The following is a description of a gene set: A process that modulates neuronal synaptic plasticity, the ability of neuronal synapses to change as circumstances require. They may alter function, such as increasing or decreasing their sensitivity, or they may increase or decrease in actual numbers. Mouse Gene Set: GOBP_REGULATION_OF_NEURONAL_SYNAPTIC_PLASTICITY studied in species Mus musculus, and this is the list of marker genes: Grin2d, Grik2, Gsg1l, Zdhhc2, Rims1, Unc13a, Nptn, Rasgrf1, Lnpep, Syp, Pmch, Drd2, Ncdn, Syap1, Hras, Syt4, Syngr1, Fcgr2b, Syngap1, Dlg4, Cln3, Vgf, Slc4a10, Shisa6, Mylk2, S100b, Nf1, Rab11a, Snca, Egr1, Agt, Cpeb1, Rab3gap1, Unc13b, Camk2b, App, Egr2 (NCBI Gene Id 13654), Grin2c, Ppfia3, Grm5, Rab3a, Camk2g, Rab5a, Rab8a, Kmt2a, Jph3, Star, Camk2d, Gsk3b, Shisa9, Arc, Syn1, Fxr1, Grin2a, Nsmf, Nog, Grin2b, Kcnn2, Camk2a, Acp4, Fxr2, Shisa8, Bdnf, Neurl1a, Slc8a2, Grik1, Kcnj10, Synpo, Kras, Ephb2, Kit, Cntn2, Atp1a3 (ATPase, Na+/K+ transporting, alpha 3 polypeptide), Fmr1, Rac1, Neto1, Chrd, Kdr, Grin1, Shank3